The following is a description of a gene set: Mouse Gene Set: GOBP_REGULATION_OF_TRANSLATIONAL_INITIATION_IN_RESPONSE_TO_STRESS Any process that modulates the frequency, rate or extent of translation initiation, as a result of a stimulus indicating the organism is under stress. studied in species Mus musculus, and this is the list of marker genes: Eif2ak1, Eif2s1, Dnajc3, Hbb-bs, Nck2, Impact, Ppp1r15a, Eif2ak4, Tmed2, Pml, Nck1, Npm1, Eif2ak3, Fech